Given this list of marker genes APOC2, LRPAP1, APOA5, LPL, APOC1, APOE, MIR379, APOC3, VLDLR, here is a description of the gene set: The process in which a very-low-density lipoprotein particle is removed from the blood via receptor-mediated endocytosis and its constituent parts degraded. studied in species Homo sapiens Human Gene Set: GOBP_VERY_LOW_DENSITY_LIPOPROTEIN_PARTICLE_CLEARANCE